The following is a description of a gene set: Any process that stops, prevents or reduces the frequency, rate or extent of transcription regulatory region DNA binding. Mouse Gene Set: GOBP_NEGATIVE_REGULATION_OF_TRANSCRIPTION_REGULATORY_REGION_DNA_BINDING species: Mus musculus, and this is the list of marker genes: Lhx2, Psen1, Hey2, Msx1, Mad2l2, Fbxw7, Id2, Msx2, Gata1, Sox11, Hand1